Given this list of marker genes COCH, TAOK3, MXRA7, ABCG2, MICAL2, MCAM, SNAP25, SUSD5, CRYBG1, QPCT, PRKD3, SORBS2, THSD7A, TCF4, here is a description of the gene set: Human Gene Set: VICENT_METASTASIS_UP studied in species Homo sapiens Bone is a frequent target of lung cancer metastasis, which is associated with significant morbidity and a dismal prognosis. To identify and functionally characterize genes involved in the mechanisms of osseous metastasis, we developed a murine lung cancer model. Comparative transcriptomic analysis identified genes encoding signaling molecules (such as TCF4 and PRKD3) and cell anchorage-related proteins (MCAM and SUSD5), some of which were basally modulated by transforming growth factor-beta (TGF-beta) in tumor cells and in conditions mimicking tumor-stromal interactions. Triple gene combinations induced not only high osteoclastogenic activity but also a marked enhancement of global metalloproteolytic activities in vitro. These effects were strongly associated with robust bone colonization in vivo, whereas this gene subset was ineffective in promoting local tumor growth and cell homing activity to bone. Interestingly, global inhibition of metalloproteolytic activities and simultaneous TGF-beta blockade in vivo led to increased survival and a remarkable attenuation of bone tumor burden and osteolytic metastasis. Thus, this metastatic gene signature mediates bone matrix degradation by a dual mechanism of induction of TGF-beta-dependent osteoclastogenic bone resorption and enhancement of stroma-dependent metalloproteolytic activities. Our findings suggest the cooperative contribution of host-derived and cell autonomous effects directed by a small subset of genes in mediating aggressive osseous colonization. The metastasis gene signature: genes up-regulated during metastasis of NSCLC (non-small cell lung carcinoma) tumors to bone. from publication Vicent S, Luis-Ravelo D, Antón I, García-Tuñón I, Borrás-Cuesta F, Dotor J, De Las Rivas J, Lecanda F (PMID 18381434)